The following is a description of a gene set: part of: Opioid Signalling species: Homo sapiens Reactome Pathway: G-protein mediated events When dissociated Galpha-GTP and Gbeta-gamma can activate or inhibit different signalling cascades and effector proteins. The precise pathways depends on the identity of the alpha and beta/gamma subtypes., and this is the list of marker genes: ADCY8, PLA2G4A, GNAI1, CAMKK2, CAMK2G, ITPR3, CAMK2B, ITPR2, CAMK2A (NCBI Gene Id 815), CALM1, AHCYL1, PRKX, ADCY4, PLCB3, CAMKK1, ITPR1, PRKACA, PDE1A, KPNA2, ADCY1, PDE1B, ADCY9, PRKAR1A, PRKAR1B, ADCY7, CAMK4, PRKACG, GRK2, ADCY3, GNAT3, PRKCG (protein kinase C gamma), ADCY2, PLCB4 (phospholipase C beta 4), PLCB2, PDE1C, CAMK2D, PRKAR2B, PRKCA, PLCB1, GNAI2, GNA14, GNA15, PRKACB, NBEA, ADCY6, PRKCD, GNAQ, PRKAR2A, GNA11, CREB1 (cAMP responsive element binding protein 1), ADCY5, GNAL, MAPK1, GNAI3